The following is a description of a gene set: studied in species Homo sapiens Human Gene Set: REACTOME_ACTIVATED_NTRK2_SIGNALS_THROUGH_RAS Activated NTRK2 signals through RAS, and this is the list of marker genes: NTRK2, SHC1, SOS1, BDNF, GRB2, NRAS, KRAS, HRAS, NTF4